Given this list of marker genes NCR3LG1, JAK2, TYK2, RASAL3, KLRF1, IL18, NCR3, IL23A, HSPH1, CD300A, ZBTB7B, BAG6, IL12A, MYC, ELF4, IL12B, IL23R, CLEC2B, LGALS3, IL15, here is a description of the gene set: Human Gene Set: GOBP_NK_T_CELL_ACTIVATION The change in morphology and behavior of a mature or immature natural killer T cell resulting from exposure to a mitogen, cytokine, chemokine, cellular ligand, or an antigen for which it is specific. studied in species Homo sapiens